The following is a description of a gene set: studied in species Homo sapiens Human Gene Set: GOBP_IMMUNE_RESPONSE_TO_TUMOR_CELL An immune system process that functions in the response of an organism to a tumor cell., and this is the list of marker genes: CD226, IL4I1, PDCD1, HMGB1, CEACAM1, IL12B, HLA-DRB1, HLA-DRB3, NECTIN2, SLC22A13 (solute carrier family 22 member 13), YWHAG, HSPD1, GSDME, PVR, HLA-A, PRF1, ADAM15, MR1, CD160, MICA, HRG, TGFB1, USP5, KLHL22, FBXO38, AHR, UFL1, HAVCR2, IL12A, CD274, MAPK3, CRTAM, PRKAA1, NKG7